The following is a description of a gene set: from publication Hu Y, Wang X, Hu B, Mao Y, Chen Y, Yan L, Yong J, Dong J, Wei Y, Wang W, Wen L, Qiao J, Tang F (PMID 31269016) Retinal Pigment Epithelium Cells studied in species Homo sapiens Human Gene Set: HU_FETAL_RETINA_RPE, and this is the list of marker genes: TMEM98, RLBP1, DSG2, SLC6A13, SNHG25, TNFRSF14, APP, IGFBP7, LHX2, ASAH1, WWTR1, TTYH3, LIPG, RFLNB, GPR180, FAM107A, YAP1, CYP2W1, MT-CO3, GALNT1, MT-ATP8, PRKCQ, SMC6, CYP27A1, BIRC7, TIMP3, STRA6, CPXM2, TEX2, VEPH1, LPL, LTBP3, PLAAT3, STT3B, PHACTR2, QPRT, COL1A2, MT-RNR2, MT-ATP6, SLC7A2, CCDC80, OSBPL1A (NCBI Gene Id 55097), ITGAV, RAB27A, SLC45A2, NUCB1, SLC38A11, FBN1, SLC35D3, TPM1 (NCBI Gene Id 7168), RAB38, SEMA3B, SERPINH1, HSPB1, PCOLCE2, LYPD1, APOE, PRDM16, GOLGA4 (golgin A4), ENPP2, MT-ND4, CDR2, TSKU, TMEM164, ATP6V1C2, CRISPLD1, GEM, MFAP3L, PTGDS, MT-CO1, LAMB2, BACE2, COL9A2, MTCO2P12, LITAF, MT-RNR1, MGST1, BHLHE40 (NCBI Gene Id 8553), PDLIM5, SDCBP, MITF, ITPKB, FNIP2, IGFBP5, PGM5, FSTL1, SLC4A4, PSAP, COL18A1, PXDN (NCBI Gene Id 7837), FGFRL1, APLP2, GPRC5C, PPARGC1A, ALDH1A3, ABCC5, MT-ND6, PDGFC, PCP4, CDO1, WFDC1, CLIC6, CST3, LRATD2, SCARB1, BEST1, MLANA, ENTREP1, TRPM1, TPP1, TMEM245, GSTP1, MTCO1P12, DDR2, NMRK2, VIM, TFPI2, MT-ND1, MYL9, SFRP5, HSD17B14, VEGFA, NHERF1, BCAS4, BMP2, CCBE1, CRIM1, CNDP1, ASB13, WLS, LTBP1, PLXNB2, LOXL1, GJA1, CA14, COLEC12, RNASE1, PDPN, MT-ND3, CTSV, SLC2A1, SOSTDC1, SLC7A8, PSAT1, RBM47, PMEL, TYR, DRD4, ABCA4, PLS3, SGK1, WWC1, KRT18, FRZB, STRIP2 (NCBI Gene Id 57464), MT-CYB, SLC22A8, GPR143, TPD52L1, KLHL3, B2M, VEGFB, ELN, TSPAN10, PDGFRB, SPARC, MT-ND2, BMP7, TYRP1, NEAT1, MYRF, SDC2, ACOT11, ITGA6, DCT, MT-ND5, CLDN19, EFEMP1, CTSD, HMGA2 (NCBI Gene Id 8091), UACA, HSD17B2, KRT8, GNG11, PARD6B, NPIPB5, GPNMB, PRDM16-DT, PGM5-AS1, CD63, CTSH, UTRN, TNS3, NCOR2, TPM2, ECHDC2, NET1, IQGAP2 (IQ motif containing GTPase activating protein 2), TACC1, ZFP36L2, VAT1L, PLAC9, SLC3A2, PRXL2A, NCCRP1 (NCCRP1, F-box associated domain containing), ELOVL7, SLC39A12, INPP5K, NOTCH2, FLRT2, BSG, PLCE1, UBAP1L, FGFR3, BMP4, SLC7A6, NPC2, SLC29A4, SLC38A8, TPRN, COL27A1, MYO5C, SFRP1, SEC14L2, NOG, SLC16A8, ADAMTSL3, CPEB4, SEMA3C, RPE65, LRAT, PBXIP1, CALD1, EMP2, CCND2 (cyclin D2), GALNT10, ID3, NFE2L1, FGFR2, CRTAP, TSPAN4, TIMP2, COL8A2, PRNP, GULP1, SULF1, CANX, NPFFR1, PLD5 (phospholipase D family member 5), TTLL4, OTX2, TRPM3, WNT2B, SERPINF1, LIN7A, SLC6A20, EZR, PLTP, DPP7, PEX7 (peroxisomal biogenesis factor 7), TMEM205, COL8A1 (NCBI Gene Id 57086), RASSF8, RGR, HSBP1L1, ZNF503, FYB2, SESN3, MTCO1P40, NBPF19, C1S, FAM13A, MTATP6P1, ITM2B, SMAD3, MET, ABHD2, FAM174B, MARVELD1, PTPN14, DHRS3, SLC5A6, MT-CO2, GNS, CTNNAL1, SLC7A5, MORN1, CPVL (NCBI Gene Id 83484), DCDC2, NBPF14, TTR